The following is a description of a gene set: Cytokines mediate cell-cell communication in the immune system and represent important therapeutic targets. A myriad of studies have highlighted their central role in immune function, yet we lack a global view of the cellular responses of each immune cell type to each cytokine. To address this gap, the authors created the Immune Dictionary, a compendium of single-cell transcriptomic profiles of more than 17 immune cell types in response to each of 86 cytokines (>1,400 cytokine-cell type combinations) in mouse lymph nodes in vivo. A cytokine-centric view of the dictionary revealed that most cytokines induce highly cell-type-specific responses. For example, the inflammatory cytokine interleukin-1β induces distinct gene programmes in almost every cell type. A cell-type-centric view of the dictionary identified more than 66 cytokine-driven cellular polarization states across immune cell types, including previously uncharacterized states such as an interleukin-18-induced polyfunctional natural killer cell state. Genes positively differentially expressed in cell type: Macrophage upon treatment with cytokine: IL-12 in mouse lymph nodes in vivo. species: Mus musculus Mouse Gene Set: CUI_MACROPHAGE_IL12_RESPONSE_UP from publication Cui A, Huang T, Li S, Ma A, Pérez JL, Sander C, Keskin DB, Wu CJ, Fraenkel E, Hacohen N (PMID 38057668), and this is the list of marker genes: Gbp7, Irf7, Calhm6, Gbp5, Stat1, Gbp2, Cxcl9, Pnp, Irgm2 (NCBI Gene Id 54396), Irf1, Ifit1, Ifi203, Iigp1, Themis2, Cxcl10, Ccl2, Ifit2, Irgm1, Eif2ak2, Serpina3g, Ccl12, Ifi204, Serpina3f (serine (or cysteine) peptidase inhibitor, clade A, member 3F), Ifi211, Igtp, Zbp1, Ifi47, Socs1